The following is a description of a gene set: studied in species Mus musculus Mouse Gene Set: TABULA_MURIS_SENIS_BRAIN_NON_MYELOID_ENDOTHELIAL_CELL_AGEING from publication Tabula Muris Consortium (PMID 32669714), and this is the list of marker genes: Id1, Arl4a, Dad1, Ldha, Emc7, Ptms, Cmtm8 (NCBI Gene Id 70031), Lrrc8a, Cfl1, Vamp5, Reep5, C1d, Acer2, Drap1, Gtf2a2, Arl2, Hint1, Snrpc, Cox8a, Pfdn2, Mrps12, Cldn11, BC028528 (cDNA sequence BC028528), Anapc11, Ap2s1, Tmed3, Rpl6, Cdkn2d, Stmn1, Krt14, Cenpx, Lxn, Clic1, Nfic, Ifitm3, Tmem250, Ier2, Rpl13a, Cox7a2l, Bri3, Prdx5, Rbm26, Eif5a, Gstp1, Cyb5a, Pcp4l1, Ece1, Mllt6, Nsd3, Cltb, Crip1, Atp5mg, Ccdc85b, Pfn1, Lamtor1, B2m, Eif1b, Gpx3, Bst2, Mdh2, Mrpl58, Klk1, Acot8, Klf13, Dctn3, Flt4, Gapdh, Fmo1, Mea1, Myl9, AW112010, Zic2, Rex1bd, Polr2e, Fth1, Gkn3, Gstm1, Mrpl51, Eef1d, Fosl2, Fam110d, Id2, Rps20, Laptm4a, Sdc4, Ndufa6, Cldn5, Rpsa, Sdhc, Rpl14, Pebp1, Gpx4, H2-D1, Cib1, Tle5, Naxe, Trmt112, Iscu, Pfdn5, Trir, Rps7, Tspo, Scand1, Ahsa1, Sod1, Mag, Ndufs8, Hsbp1, Spag7, Rpl32, Lsm2, Mgst1, Gm2a, Pdrg1, Tmsb10 (NCBI Gene Id 19240), Gng11, Ifi27, Clpp, Cst3, Ostc, Ccdc12, Rnaset2b, Rpl18a, Smad7, Tma7, Rps27, Stmn2, Icam2, Dynlrb1 (NCBI Gene Id 99273), Arhgdia, Cd74, Kmt2b, Pglyrp1, Mir24-2, Exosc5, Ldhb, Mbp, Alpl, Rbm8a, Rpl35, Mageh1, Psmb2, Bad, Rpl3, Ndufa11, Plp1, Psmc3, Adrm1, Pigp, 0610010K14Rik, Cox4i1, Furin, Spcs1, Plscr1, Atp6v1f, Capg, Tex261, Nabp2 (nucleic acid binding protein 2), Ssbp4, Atp5mc2, Cavin3, H2az1, Ndufs7, Ubb, Ndufb9, Inpp4a, Tubb5, Aplp1, Wbp2, Szrd1, H2-Ab1, Zscan26, Pdcl3, Mmp24os1, Polr2g, Arpc3, Oaz1, Tmsb4x, Rplp1, Tmem234, Rps5, Rnase4, Brk1, Cox5a, Swi5, Kdelr1, Selenok, Ndufb7, Acta2, Egfl7, Ndufv2, Bsg, H3f3b, Psmb6, Tubb4a, Tpi1, Atp5if1, Rbm39, Krt15, Ckb, Ppib, Rpl11, Rps13, Cystm1, Ifitm2, Psmd4, Eif3k, Txn2, Atp6v0c, Park7, Tcf15, Twf1, Nedd8, Pkig, Skil, Fkbp2, Rps18, Syf2, Eif6, Bcl7c, Aldoa (aldolase A, fructose-bisphosphate), Hint2, Gadd45gip1, Ramp2, Atp6v0e, Ly6a, Csnk2b, H2az2, Lypd8, Plekhb1 (pleckstrin homology domain containing, family B (evectins) member 1), S100a6, Klf4, Polr3gl, Dhrs3, H2-Q6, Pin1, Gpm6b, S100a11, Znhit1, Tmem50a, Rbm42, Fdx1, S100a1, Psmb9, Chmp2a, Tmbim4, Rpl9, Atp5pd, Atp5mc3 (NCBI Gene Id 277484), Dpysl2, Arl3, Smco4, Vwf, Krt8, Vti1b (vesicle transport through interaction with t-SNAREs 1B), Prr13, Hrct1, Ndufc2, Lgals4, BC031181, Tmed9, Rtf1, Serf2, Ndufb8, Ankrd37, Sf3b4, Emc4, Commd1, Nudt3, Elof1, Zfp36, Ptma, Crip2, Ddrgk1, Tspan4, Ppp1r11, Ubald1, Pomp, Tmem176b, Rhoc, Micos13, Apoa1, Map1lc3a, Sub1, Lamtor4, Lamtor2, Fis1, Apoe, Zmat5, Ddhd2, Rpl34-ps1, Cyba, BC005624, Rabac1, 1810037I17Rik, Mtarc2, H2-K1, Krt18, Fmo2, Mien1, Ier3, Rdm1, Gatad1, Trf, Anxa2, Smdt1, Ccdc124, Vps28, Ndufb10, Smim14, Cd9, Spr, Calm2, Ftl1, Atp6v1g1, Depp1, Atp5mc1, Psenen, Rps3 (NCBI Gene Id 52418), Jund, Rps9, Bloc1s1, Cdk2ap2, Syt11, Vamp8, Plaat3, Clu, Ptgds, Klf2, Gabarapl2, Ndufb11 (NADH:ubiquinone oxidoreductase subunit B11), Tmem160, Chrac1, S100a13, Mgp (NCBI Gene Id 223886), Fxyd5, Myl12a, Cnp, Mif, Kdm6b, S100a16, Marf1, Gstm2, Calm1, Selenow, Rpl24, Atp5f1d, Sf3b2, Snrpb, Rpl13, Smim30, Sft2d1, Zfpl1, Akt1s1, Ubb-ps, Slc25a5, Pttg1, Gnb1, Trappc3, Dynll1, Selenom, Hdac7, Ndufa12, Klf7, Mobp, Sh3bgrl3, Copz2, Tomm6, Psmb3, Tceal9 (NCBI Gene Id 99775)